The following is a description of a gene set: Mouse Gene Set: GOBP_PHOSPHATIDYLETHANOLAMINE_ACYL_CHAIN_REMODELING studied in species Mus musculus Remodeling the acyl chains of phosphatidylethanolamine, through sequential deacylation and re-acylation reactions, to generate phosphatidylethanolamine containing different types of fatty acid acyl chains., and this is the list of marker genes: Mboat2, Pla2g2f, Pla2g4c, Mboat1, Lpcat3, Lpgat1 (lysophosphatidylglycerol acyltransferase 1), Lpcat4